Given this list of marker genes SPAG5, SMC2, SHCBP1, CKS2, CENPE, CENPF, CCNB2, FOXM1, NCAPH, CDC20, KIF4A, ZWINT, DLGAP5, NDC80, GMNN, TTK, MELK, ASPM, PLK4, OIP5, RFC4, PRC1, NUSAP1, MCM4, MT1JP, TYMS, UBE2S (ubiquitin conjugating enzyme E2 S), HMGB2, TOP2A, CDCA8, UBE2C, CKAP2, KIF11, BUB1B, BIRC5, KIF2C, KIF20A, NSD2, RRM2, PCNA, RRM1, PBK, H2AX (NCBI Gene Id 3014), FEN1, SMC4, PTTG1, KIF18B, CDCA3, HMMR, MCM2, ESPL1, RACGAP1, CCNA2, BUB1, CDK1, TPX2, AURKA, here is a description of the gene set: studied in species Homo sapiens Human Gene Set: GNF2_CCNB2 Neighborhood of CCNB2 cyclin B2 in the GNF2 expression compendium Neighborhood of CCNB2